Given this list of marker genes Slc31a1, Atp7a, Steap2, Slc31a2, Steap3, Steap4, Steap1, Atp7b, here is a description of the gene set: studied in species Mus musculus Mouse Gene Set: GOBP_COPPER_ION_IMPORT The directed movement of copper ions into a cell or organelle.